Given this list of marker genes PTPN20, ZBTB39, CTDSPL2, TRIM9, ZNF25, NAA50, BCL2L11, KMT5A, TRPS1, LGI1, SDC4, LRRC9, CDK19, CHD6, CHD1, LIMK2, RAB6B, DNMT3A, PTPN12, WAPL, TARDBP, SUFU, ARK2N, HS3ST2, SLC30A8, SAMTOR, QKI, RSBN1L, VAPA, MECP2, MIB1, GLIS3, PFKFB2, EHBP1, DMD, TJAP1, SUMO2, CHD9, RTL3, CLLU1, SEPHS1, GABRB3, EPC2, RAB11FIP2, SLC2A3, ST18, MIDEAS, CSNK1D, SPCS2, ZFHX4, LRRFIP1, SOCS2, TAF4, TGIF1, GIPC1, OSBPL11, AGO1, HBEGF, COLCA1, BTBD7, RSBN1, TMEM43 (transmembrane protein 43), TRIM23, DUSP9, GYG1, ZNF395, FMR1, ARHGAP5, GRHL2 (NCBI Gene Id 79977), TSPAN7, ARHGAP21, ARID2, LIN28B (NCBI Gene Id 389421), DEPDC1B, TTC7B (tetratricopeptide repeat domain 7B), CEP350, ASAP1, NFAT5, MBNL2 (NCBI Gene Id 55479), TLN2, MRPL35, NCL, MYRF, PITPNM2, GMFB, HNF1B, ITSN1, UBR3, FOXA1, HOOK3, EXOC5, TBC1D25, AP1G1, ERGIC2, MID1IP1, TEFM, GRHL3, SNX1, YTHDF1, NUDC, PAN3, MEIS2, CHD4, PDHB, STX16, FBXW7, KLF12, TRIP12, here is a description of the gene set: Genes having at least one occurence of the motif CTGTTAC in their 3' untranslated region. The motif represents putative target (that is, seed match) of human mature miRNA hsa-miR-194 (v7.1 miRBase). Human Gene Set: CTGTTAC_MIR194 studied in species Homo sapiens